Given this list of marker genes HOOK3, CPA3, ANKRD29, GORAB, DUSP6, CCDC51, PAWR, RLF, ZIM3, PLPPR4, ALCAM, C5orf22, PAX9, EIF3J, ZNF451, AUTS2, SLC7A5, CRKL, ERCC6, MSX2, PI15, PPM1A, TRIM58, TMEM38B, VIM, SASS6, WDR26, PGK2, NDN, SMIM15, PEDS1-UBE2V1, PRKAR2A, ZNF131, RFTN1, SESTD1, SHROOM2, JAZF1, TMEM134, PPARA, RSF1, INA, PSIP1, CHD1, RAPH1, CPSF6 (NCBI Gene Id 11052), SMG1, TMEM170B, RIMS1, SECISBP2L, KDM2A, PMEPA1, INVS, DPY19L1, RPS6KA6, KIAA1217, MIER3 (NCBI Gene Id 166968), SLC6A8, CCNT2, HIVEP2, BEST3, UBE2E1 (ubiquitin conjugating enzyme E2 E1), USP27X, NEFL, ATAD1, GPALPP1, UBE2V1, PGAP2, DGKK, GPR37, KIAA0408, DAB2, IQCJ-SCHIP1, ZBTB18, NUDCD1, LRRN1, SLC25A53, NPEPPS, NEXMIF, EGR4, GRIP1, CD44 (CD44 molecule (IN blood group)), TMEM236, LHFPL2, GOLGA7, TXLNG, TDRD3, TFEB, SPARC, REPS2, SLC20A1, DYNLT1, UNKL, CDYL2, SHROOM3, CYSTM1, NR1D2, ELF3, EML6, IGSF11, YWHAH, GRAMD4, SH3KBP1, LGR4, FHIP2A, NRARP, ANXA4, RAB30, CCR2, STRN3, DPYSL5, PRKAR1A, USP38, COL6A3, MSL2, MACC1, CELF2, NFAT5, ZNF117, ARMCX5, CREBZF, ANKRD13B, ST8SIA1, ELAVL2, GGCT, LEPR, ZNF598, SOCS5, CERT1, RAB21, NCOA7, SCHIP1, FEM1B, AK7, ADAMTS6, CITED2, here is a description of the gene set: species: Homo sapiens Genes predicted to be targets of miRBase v22 microRNA hsa-miR-585-5p in miRDB v6.0 with MirTarget v4 prediction scores > 80 (high confidence targets). Human Gene Set: MIR585_5P from publication Chen Y, Wang X (PMID 31504780)